The following is a description of a gene set: Human Gene Set: GOBP_RETINOIC_ACID_METABOLIC_PROCESS studied in species Homo sapiens The chemical reactions and pathways involving retinoic acid, one of the three components that makes up vitamin A., and this is the list of marker genes: RDH10, ADH1B, CYP26B1, DHRS9, UGT1A1, CYP26A1, CRABP2 (cellular retinoic acid binding protein 2), CYP2W1, UGT1A7, PRMT3 (NCBI Gene Id 10196), CYP2C18, SCPEP1, CYP2S1, CYP27C1, UGT1A3, ALDH1A2, ALDH1A3, ADH1C, CYP3A5, RBP1, UGT1A9, ADH1A, ADH7, UGT1A8, ALDH8A1, CYP1A1, CYP3A4, BCO2, ADH6, CYP26C1, CYP2C8, CYP3A7, AKR1C3